Given this list of marker genes ATP5F1B, BCKDK, BCKDHB, DLD, PPM1K, BCAT2, here is a description of the gene set: Human Gene Set: HP_ABNORMAL_CIRCULATING_ISOLEUCINE_CONCENTRATION Any deviation from the normal concentration of isoleucine in the blood circulation. species: Homo sapiens Abnormal circulating isoleucine concentration